Given this list of marker genes H4c8, H3c2, H3c8, Ezh2, H2ac6, H2bc15, H2bc3, H2ac11 (H2A clustered histone 11), H2ac15, H2ac19, H4c9, H2ac10, H2ac13, H2bc26, Dnmt3a, H3c11, H4c4, H2bc24, H2bc13, Aebp2, H3c7, H2bc11, H4c3, H2bc4, H2az2, H4c6, H4c1, Dnmt1, H2bc6, H2ac18, H3c3, Rbbp4, H2aj, H4c14, H2bc23, H2bc22, H4c11, H2bc21, H2ac20, H2ac7, H3c13, H2bc14, H2bc7, H3f3a (H3.3 histone A), H2ab2, Phf19, H2bc1, H2bc9, Jarid2, Rbbp7, Mtf2, Dnmt3b, H2ax (NCBI Gene Id 15270), H2bc12, H2ab3, H2ac12, H2ac23 (H2A clustered histone 23), H2bc8, H3f3b, H3c10, H3c15, H2ac24, Suz12, H3c6, H2ab1, H3c14, H4c12, H4c16, H3c1, Eed, H4c17, H2ac22, H4c18, H3c4, H2ac4, H4c2, H2ac8, Phf1, here is a description of the gene set: PRC2 methylates histones and DNA Mouse Gene Set: REACTOME_PRC2_METHYLATES_HISTONES_AND_DNA species: Mus musculus